Given this list of marker genes Ephb4, Fyn, Sdcbp, Arhgef7, Efnb1, Rac1, Nck2, Efnb2, Pak2, Src, Ephb3, Git1, Ephb1, Ephb6, Efnb3 (NCBI Gene Id 13643), Ephb2, Pak3 (NCBI Gene Id 18481), Pak1, here is a description of the gene set: Ephrin signaling Mouse Gene Set: REACTOME_EPHRIN_SIGNALING studied in species Mus musculus